The following is a description of a gene set: Any process that modulates the frequency, rate, or extent of cell-cell adhesion mediated by integrin. species: Homo sapiens Human Gene Set: GOBP_REGULATION_OF_CELL_CELL_ADHESION_MEDIATED_BY_INTEGRIN, and this is the list of marker genes: FERMT3, CD3E, SKAP1, ADA, PODXL, WNK1 (NCBI Gene Id 9872), CXCL13, DPP4 (NCBI Gene Id 1803), CCL5, SWAP70, PIEZO1